Given this list of marker genes ITGA4, ITGA9, JAK2, ANGPT1, MLST8, G6PC3, GYS1, LAMA3, COMP, RPS6, EIF4E, SOS1, PPP2R2A, ITGB8, TNXB, RELA, FLT3LG, TLR2, PHLPP2, PDGFA, ITGA10, CD19, IFNA13, NFKB1, IL6R, EGFR, MDM2, FLT1, FGF11 (fibroblast growth factor 11), COL9A2, DDIT4, STK11, FGF6, PIK3R2, PIK3R1, BCL2, CREB3, CCND1, CSF3R, PIK3CD, PRKAA2, LPAR1, EIF4E2, CCNE1, GH2, COL1A2, EFNA1, AKT3 (NCBI Gene Id 26068), ITGA7, PKN1, HSP90B1, PCK1, GNB5, PIK3R5, IL3RA, IL2RB, FGFR3, CSH1, COL6A5, MAPK3, COL4A1, VEGFA, IFNA2, FGF5, IL2, MAP2K1, CSF1, CSF1R (NCBI Gene Id 8156), ITGA2, ITGB1, KIT, EFNA2, GNB2, CDK4 (NCBI Gene Id 92978), EPHA2, CDK2, ITGA5, EFNA5, FN1, PPP2R3B, LAMA5, CREB1, LPAR5, FGF9, VEGFD, FGF3, FGF18, SGK1, PPP2R5C, PPP2R5B, LAMB4, GNGT1, THBS1, TCL1B, IL4R, THEM4, NOS3, PIK3AP1, VTN, PRL, IFNAR2, IL2RG, THBS4, AKT1, BDNF, FLT4, IKBKG, INS, LAMA4, GNG11, KRAS, RAF1, CREB3L1, ITGB5, IFNAR1, CHAD, IL7R, GNG10, TCL1A, BRCA1, SPP1, COL4A3, OSM, FASLG, FGF7 (fibroblast growth factor 7), IFNA7, SGK3, COL9A1, HGF, RPTOR, CSF3, COL4A2, EFNA4, FGF20 (NCBI Gene Id 26281), PDPK1, GNG7, PRLR (prolactin receptor), PDGFRB, IRS1, SYK, ITGB4, IFNA5, PDGFB, CCNE2, IBSP, TNC, CASP9, OSMR, IFNB1, GH1, PPP2R1B, NTF4, IFNA14, COL6A2, PDGFD, CCND2, MTOR, GNB3, ANGPT2, FGF22, RHEB, MYC, ITGA6, GHR, CDKN1B, PPP2R2D, FGF21, IFNA16, COL4A4, PPP2R5D, CHRM1, THBS3, FGF13, MYB, FGF4, IL7, GNG5 (G protein subunit gamma 5), BAD, FOXO3, FGF1, MET, FGF17, CHRM2, NGF, IGF2, PPP2R3C, IFNA8, GNG13, HRAS, IKBKB, RPS6KB1, ITGA11, BCL2L1, PIK3CA, PPP2R5A, GYS2, IL2RA, ITGA1, FGF19, EIF4E1B, PIK3CG, FGF10, ITGA2B (integrin subunit alpha 2b), PDGFC, PRKCA, PIK3R6, GNG12 (G protein subunit gamma 12), SOS2, PKN3, PPP2R2C, VEGFB, EFNA3, PPP2CB, G6PC1, ITGA3, PKN2, F2R (NCBI Gene Id 2149), IFNA17, ATF6B, FLT3, ITGAV, VEGFC, JAK3, TEK, IFNA21, FGF23, LAMB3, HSP90AB1 (NCBI Gene Id 3326), JAK1, EIF4EBP1, KDR, TLR4, NTRK1, MAPK1, COL6A6, CREB3L3, KITLG, CDC37, MAP2K2, PRKAA1, GNB1, PTEN, CDKN1A, LAMC2, PHLPP1, GNG3, IL3, G6PC2, PPP2R2B, CDK6, ANGPT4, RBL2, COL6A3, GNG4, IFNA10, FGFR1, EPO, LPAR4 (NCBI Gene Id 2846), ATF4, LPAR2, SGK2, FGF8, FGFR4, TNN, PIK3CB, COL6A1, CHUK, LAMC3, HSP90AA1 (NCBI Gene Id 89272), AKT2, ITGB6, GNB4, LPAR6, TSC2, NTRK2, IGF1R, PDGFRA, IFNA6, PIK3R3, PTK2, FGF2, TP53, GSK3B, COL4A5, ATF2, CREB5, RELN, BCL2L11, NGFR, LAMB2, CREB3L4, ITGB7, COL9A3, FGFR2, ITGA8, MCL1, IFNA4, PPP2R3A, CCND3, NRAS, LPAR3, INSR, LAMA2, LAMB1, COL4A6 (NCBI Gene Id 1288), ITGB3, FGF14, PPP2CA, RPS6KB2, IFNA1, PCK2, LAMA1, TGFA, LAMC1, TNR, GNGT2, EGF, NTF3, IL6, FGF12, PGF, EPOR, GNG8, EIF4B, VWF, RAC1, PPP2R5E, COL1A1, PPP2R1A, GNG2, IGF1, COL2A1, THBS2, CSH2, TSC1, IL4, CREB3L2, ADAMTSL4-AS1, GRB2, here is a description of the gene set: studied in species Homo sapiens Human Gene Set: WP_PI3KAKT_SIGNALING PI3K-Akt signaling